Given this list of marker genes Srf, Map3k10, Rlim, Trim40, Cyp1b1, Csrp3, Kit, Dab2ip, Slco3a1, Il18, Ralgapa1, Taf3, Irak1, Msx2, Trim32, Zc3h12a, Wnt5a, Ppp2r5b, Tlr3, Tnfsf11, Dhx9, Ppp2cb, Nr1h4, Irak3, Trim26, Spop (NCBI Gene Id 20747), Pim1, Tssk4, Clu, Adora3, Xcl1, Id2, Adgrf1, Cactin, Bud31, Ikbkg, Stk36, Bdnf, Lpar5, Men1, Trim12a, Fzd1, Rps3, Myd88, Crnn (NCBI Gene Id 630883), Cdk5rap3, Sox6, Rwdd1, Bex2, Nlrp3, Ptgis, Il6, Il1b (interleukin 1 beta), Traf5, Carf, Nwd1, Mapk3 (NCBI Gene Id 26417), Camk1d (NCBI Gene Id 320468), Rbck1, Trim62, 4930447C04Rik, Tnfsf18, E130311K13Rik, Cys1, Dhx33, Arhgef5, Trim37, Prdx3, Ikbke, Klf4, Aim2, Ppia, Chp1, Hmgn3, Cd200, Neurog1, Foxs1, Hdac3, Havcr2, Tgfbr3, Card14, Eomes, Lrp6, Trim15, Fzd2, Mad2l2, Erc1, Sirt1, Il18rap, Ezh2, Nlrc5, Usp7, Ifrd1, Nr0b2, Hdac2, Ngf, Paxip1, Rnf220, Ins2, Ddit3, Rgcc, Neurog2, Mtpn, Cd40lg, Chuk, Esr1, Tlr4, Heyl, Traf6, Rps6ka5, Cops5, Adcy1, Tax1bp1, Nlrp12, Fanca, Tmigd3, Ikbip, Trim30c, Mir205hg, Cib1, Card9, Trim31, Id3, Fer, Acod1, Card11, Ctnnbip1, Foxp3, Trib1, Prox1, Prkd2, Esr2, Terf2ip, Cdkn2a, Kdm5a, Arhgef2, Trim30a (tripartite motif-containing 30A), Ddr2, Dvl2, Crebbp, Foxj1 (NCBI Gene Id 15223, forkhead box J1), Rtkn2, Dap, Brms1, Commd7, Ikbkb, Ppargc1a, Spi1, Rwdd3, Prkcz, Prkch, Commd6, Rhebl1, Pkhd1, Epha5, T, Hdac4, Trim38, Cd40, Nr0b1, Bhlhe40, Zic3, Wnt2, Mtdh (metadherin), Ppp3ca, Tut4, Ptch1, Prdx2, Crtc3, Ltf, Atf2, Pycard (NCBI Gene Id 66824), Myocd, Trim21, Trim12c, Pla2g10, Prmt2, Il10, Malt1, Rab7b, Il18r1, Neurod1, Lamtor5, Traf2, Tfrc, Bcl3, Pex14, Nfix, Med13, Zbtb7a, Commd1, Map3k13, Trim14, Hipk2, Ndn, Crebzf, Zc4h2 (NCBI Gene Id 245522), Mturn, Fancd2, Tnf (tumor necrosis factor), Ep300, Cth, Nkx3-1, Hck, Nupr1, Sik1, Nfkbil1, Pten, Kdm8, Smarcb1, Hsf1, Ror1, Lrrfip1, Cflar, Tirap, Jup, Hdac5, Cd84, Pthlh, Trim27, Anxa3, Wwp2, Gfi1, Edn1, Eif2ak4, Capn3, Pura, Il5, Arrb2, Pou4f2, Peli1, Mavs, Psmd10, Pias4, Ripk2, Tnfrsf11a, Nts, Il4, Cmklr1, Il1rap, Tnfaip3, Sting1, Prkd1, Tlr2, Foxh1, Hspa1b, Tcf3 (transcription factor 3), Anxa4, Crtc1, Foxa2, Trim30b, Fank1, Traf1, Cyld, Reln, Zic2, Otulin, Prkcq, Neurod2, Crtc2, Fzd6, Cat, Glis2, Grem1, Parp10, Trim13, Park7, Sumo1, Ticam1, Sp100, Ar, Fzd4, Trappc9, Tcf7l2, Rnf2, Smarca4, Trib2, Nod2, Arid5b (AT-rich interaction domain 5B), Igf1r, Id1, Cytl1, Carm1, Irak2 (NCBI Gene Id 74787), Nod1, Foxa1, Flna (filamin, alpha), Eif2ak2, Nfkbid, Ntrk1, Hand1, Trim25, Pias2, Ripk4, Wnt10b, Psma6, Ube2n, Tnfsf4, Nlrc3, Zfp932, Ripk1, Sphk1, Clock, Akt1, Ankrd42, Setd6, Lrrc14, Sfrp4 (NCBI Gene Id 20379), Bcl10, Plpp3, Fcgr2b, Pbx1, Mid2, Nlrc4, Trim30d, Erbin, Hand2, Wnt3a, Thap11, Enpp1, Adcy8, Cebpg, Pou4f1, Rela, Tnfrsf4, Trim8, Traf3, Adgrg3, Mapk1, Prkci, Ripk3, Siva1, Trim5, Ufl1, Tbx6, Lrrfip2, Phb2, Syk (spleen tyrosine kinase), Pparg, Bmp2, Itch, Npm1, Rnf25, Egln1, Arrb1, Rnf31, Trim52, Dnaja3, Camk2a, Ager, Traip, Ins1, Nodal, Kat6a, Ddrgk1, Kdm1a, Tceal7, Nfkbia, here is a description of the gene set: species: Mus musculus Mouse Gene Set: GOBP_REGULATION_OF_DNA_BINDING_TRANSCRIPTION_FACTOR_ACTIVITY Any process that modulates the frequency, rate or extent of the activity of a transcription factor, any factor involved in the initiation or regulation of transcription.